Given this list of marker genes KERA, RNF214, KATNBL1, CAB39L, CYP2J2, AHR, CST11, NDEL1, LYN, PDE4B, PRPF38A (pre-mRNA processing factor 38A), REM2, FKBP1A, KCTD11, MAPKAPK5, SAPCD1, IER3, CDH15, RRP36, ZFPL1, KSR1, FSCN1 (fascin actin-bundling protein 1), TSPAN5, GOSR1 (golgi SNAP receptor complex member 1), NUDT9, CST3, UPF2, ACADSB, PTGES, POFUT2, RANBP1, ILF3, DHPS, RUSC2, TSPAN33, SNX16, SLC6A4, TCF20, CMTM6, KAT2B, PALLD, MZF1, PSMA6, IFT172, SLC26A7, CCNE1, BNIP2, CACNG6, CACYBP, PDE1A, CD14, UBA1, CX3CL1, ADAMTSL5, PTPRJ, UBE2D1, ETNK1, HARS1, FKBP11, TCP10L, CCL2, PDSS1, LRRC58, NMD3 (NMD3 ribosome export adaptor), TIMP1, RND3, TAB2, SLC31A1, CWC15, ATP6V1E1, SLC39A8, SERPINA3, SLC6A13, ASPN, HGD, EPGN, SLC5A11, MACROH2A1, SPTB, MAP3K8, HK2, PSMA4, MECR, LYVE1, PTPN23, BPIFA2, LAMB3, CACNA1F, HNRNPH3, CYSTM1, KATNA1, RTCA, ACVR1, DDHD1, FBXW11, GTPBP2, SEMA4G, TMEM121B, CNN3, LNX1, NHP2, MBD2, TANC1, SPRR2F, IL18, SLPI, NPPA, DACH1, ZFPM2, TRIM26, LMAN1L, FURIN, EIF4G1, NKG7, PLAC9, TMEM39A, CNTFR, ARTN, DOK5, MMP2, REPS1, GINM1, SLCO1A2, TRPM6, WFS1, AGTRAP, VRK2 (NCBI Gene Id 7444), RBM19, RBM7, DAB2, SLFN12L, PCDH18, F11R, PIWIL1, HINFP, SIT1, DHX58, TGFA, ZNG1B, KREMEN1, POLB, POLR2C, KMT5A, CXCL6, PACC1, TTC39B, LLGL2, USP25, STXBP1, KLRK1 (killer cell lectin like receptor K1), ASPRV1, SNCG, MPP1, SFRP1, GCA, COL11A1, PACRG, TP53RK, RASA2 (NCBI Gene Id 5922), CALCR, NUB1, DENR, MSN, ICOS, KCNA4, CHD1, SLC8A2, PLEKHF2, PRPF38B, LIG3, FGL2, ARF4, PLSCR1, PHC2, MMP14, MAGED2, CCL1, IGF2BP1, PTPN11, NUP58, TBK1, CENPT, NHERF1, PHF13, MAD2L2, MTF2, ARCN1, ZNRF1, TMEM79, NRROS, HOMER1, NANOG, CLCF1, C5orf15 (chromosome 5 open reading frame 15), C11orf71, PARG, PPIE, PPIF, CD44, here is a description of the gene set: Genes down-regulated in comparison of control dendritic cells (DC) at 6 h versus those stimulated with LPS (TLR4 agonist) at 6 h. mouse primary BMDCs were stimulated with tlr ligands and gene expression changes were profiled on Affymetrix arrays species: Homo sapiens Human Gene Set: GSE17721_CTRL_VS_LPS_6H_BMDC_DN from publication Amit I, Garber M, Chevrier N, Leite AP, Donner Y, Eisenhaure T, Guttman M, Grenier JK, Li W, Zuk O, Schubert LA, Birditt B, Shay T, Goren A, Zhang X, Smith Z, Deering R, McDonald RC, Cabili M, Bernstein BE, Rinn JL, Meissner A, Root DE, Hacohen N, Regev A (PMID 19729616)